The following is a description of a gene set: Human Gene Set: GOBP_AV_NODE_CELL_TO_BUNDLE_OF_HIS_CELL_SIGNALING species: Homo sapiens Any process that mediates the transfer of information from an AV node cardiac muscle cell to a bundle of His cardiomyocyte., and this is the list of marker genes: GJA5, SCN10A, SCN5A, RYR2, TRPM4, CACNA1C, CXADR, CACNA1G, CACNB2, MIR208A, SCN4B